Given this list of marker genes Crppa, Tnip2, Phtf2, Ntrk2, Frrs1l, A3galt2, Usp54, Pacs2, Zkscan17, Fbxo46, Phospho1, Arfip2, Itpr1, Sec14l3, Srpra, Pex11g, Phldb1, E2f4, Dgkg, Gdi2, St3gal1, Rasal1, Kcna6, Ankrd54, Rph3a, Cdk5r1, Rnf122, Akap12, Fgd4, AI661453, Sec24c (SEC24 homolog C, COPII coat complex component), Rab27a, Gmeb2, Slc9a8, H2bc6, Trabd2b, Clcn5, Ncl, Zswim6, Hmgcr, Kcnb1, Mllt1, Grk5, Mapt, Heyl, Ireb2, Impa2, Sptbn4, Egr1, St6galnac1, Bet1l, Slco3a1, Tyr, Tbc1d5, Acvrl1, Ccdc120, Pnkd, Rassf1, Znhit6, Tnip1, Mfsd8, Zmiz1, Wsb1, Morc2a, Tbc1d2, Cdr2l, Pde2a, H2bw2, Scyl1, Dtx4, Slc25a34, Wdr20, Bclaf1, Atp2b2, Nsmaf, Rab43, Kctd5, Ngfr (nerve growth factor receptor (TNFR superfamily, member 16)), Necap1, Htt, Git1, Adam12, Zwilch, Sertad4, Adcy1, Qrich1, Iqsec3, Bmal1, Dlgap1, Zyx, Tyw3, Txn2, Ephb2, Paqr4, Gpatch8, Sema5a, Ube2h, Haspin, Apc2, Gng7, 6430548M08Rik (NCBI Gene Id 234797), Spmip4, Chrnb2, Phf20, Piga, Slc6a1, Suv39h1, Clk3, Hibadh, Ahdc1, Map2k1, Tspan11, Bank1 (NCBI Gene Id 99642), Hsd17b6, here is a description of the gene set: Mouse Gene Set: MIR_760_3P from publication Chen Y, Wang X (PMID 31504780) Genes predicted to be targets of miRBase v22 microRNA mmu_miR_760_3p in miRDB v6.0 with MirTarget v4 prediction scores > 80 (high confidence targets). studied in species Mus musculus